Given this list of marker genes RPGRIP1L, EPHB2, ZEB2, KCNA2, RTN4RL2, ATG16L1, RTN4R, NSUN5, WDR89, CORO1C, NIN (NCBI Gene Id 57681), LPAR1, WDR37, C12orf57, KCNC1, HERC1, FILIP1, WDR47, SZT2, EPHB3, PAFAH1B1 (platelet activating factor acetylhydrolase 1b regulatory subunit 1), TSKU, PTPRS, CDK5, RYK, RTN4RL1, PRDM8, here is a description of the gene set: Human Gene Set: GOBP_CORPUS_CALLOSUM_DEVELOPMENT The process whose specific outcome is the progression of the corpus callosum over time, from its formation to the mature structure. The corpus callosum is a thick bundle of nerve fibers comprising a commissural plate connecting the two cerebral hemispheres. It consists of contralateral axon projections that provide communication between the right and left cerebral hemispheres. studied in species Homo sapiens